The following is a description of a gene set: species: Mus musculus Mouse Gene Set: GOBP_PEPTIDYL_TYROSINE_DEPHOSPHORYLATION The removal of phosphoric residues from peptidyl-O-phospho-tyrosine to form peptidyl-tyrosine., and this is the list of marker genes: Ptpn9, Ptprf, Dusp1, Ptprb, Ptpn11, Dusp22, Dusp18, Epm2a, Ptprj, Ptpro (protein tyrosine phosphatase receptor type O), Dusp5, Ptpn12, Tns2, Dusp7, Dusp3, Ptprz1, Ptprh, Dusp10, Acp4, Ptprs, Ptpn2, Dusp6, Ptprt, Ubash3b, Ptpn13, Dusp21, Ptpn6, Ptpn1